Given this list of marker genes NOTCH3, PLPP3, PRNP, PSMF1, ADM, SLC7A5, COL3A1, HDLBP, ACTN2, BHLHE40, CSNK2A1, SIRPA, SLC3A2, PLXNB2 (plexin B2), CAD, DLC1, HLA-B, HSP90B1, IMPDH1, GPI, LOXL1, CNTN2, COL4A2, ACTA2, MARS1, AKT2, HSPA5, PKN1, PYCR1, CITED2, SLC16A3, RND3, SLC1A5, ACTG1, CDH13, CBLB, RUSC2, FSTL1, GABRA5, BCAM, PTTG1IP, EIF4A1, IGFBP7, ANKRD1, NID1, CALR, here is a description of the gene set: Genes down-regulated in chondrosarcoma and ovarian carcinoma cell lines which developed resistance to trabectedin. species: Homo sapiens ET-743 (Yondelis(TM), Trabectedin) isolated from the tunicate Ecteinascidia turbinata, is being tested in phase II clinical trials in Europe and the United States of America (USA). Studies with different solid tumours have shown antitumour activity in advanced, pre-treated sarcomas as well as in drug-resistant breast and ovarian cancer. The primary mechanism of action for ET-743 has not been fully elucidated and different models have been suggested to explain its molecular mechanism of action. ET-743 binds tightly to the minor groove of DNA and previous data have suggested that ET-743 acts by interfering with RNA transcription. To further investigate the mechanism of in vitro drug resistance, we evaluated the gene expression profile in ovarian and chondrosarcoma cell lines selected for resistance to ET-743. We found genes whose expression was modulated in both drug-resistant cell lines when compared with their respective parental drug-sensitive cell lines. This pattern of gene expression seems to be selective for ET-743-resistant cells, since ovarian cancer cells resistant to paclitaxel did not share the same gene expression changes. Data presented in this study reveal different molecular pathways that could be involved in the cellular mechanism of ET-743 resistance. from publication Marchini S, Marrazzo E, Bonomi R, Chiorino G, Zaffaroni M, Weissbach L, Hornicek FJ, Broggini M, Faircloth GT, D'Incalci M (PMID 15661559) Human Gene Set: MARCHINI_TRABECTEDIN_RESISTANCE_DN